The following is a description of a gene set: Human Gene Set: HP_BLUE_IRIDES A markedly blue coloration of the iris. Blue irides species: Homo sapiens, and this is the list of marker genes: BLOC1S3, EDNRB, UBE3A, PTPN11, TMEM270, PDE4D, MC1R, VPS37D, RAF1, SOS1, METTL27, RRAS, FKBP6, BUD23, SPRED2, KITLG, OCA2, PRR12, SNRPN, ELN, RIT1, GTF2IRD1, PAH, GTF2IRD2, EIF4H, CBL, SLC45A2, CLIP2, RASA2, NRAS, SOS2, MAPK1, GTF2I, MRAS, RFC2 (replication factor C subunit 2), MITF, NCF1, BAZ1B, EDN3, TYR, RRAS2, LIMK1, TYRP1, DNAJC30, PAX3, KRAS (NCBI Gene Id 3845), RLIM, TP63, TBL2, PRKAR1A, LZTR1, MLXIPL, STX1A, SOX10, HERC2